The following is a description of a gene set: Human Gene Set: GOMF_NUCLEOSIDE_DIPHOSPHATE_KINASE_ACTIVITY species: Homo sapiens Catalysis of the reaction: ATP + nucleoside diphosphate = ADP + nucleoside triphosphate., and this is the list of marker genes: NME9, NME4, AK9, CMPK2, NME6, AK7, NME3, AK1, NME2P1, NME5, DTYMK, AK5, NME7, AK8, CMPK1, NME1, AK4, NME2